The following is a description of a gene set: studied in species Homo sapiens Genes up-regulated in HeLa cells (cervical carcinoma) at 30 min after stimulation with TNF. Tumor necrosis factor alpha (TNF alpha) is a proinflammatory cytokine with important roles in regulating inflammatory responses as well as cell cycle proliferation and apoptosis. Although TNFalpha stimulates apoptosis, it also activates the transcription factor NF-kappa B, and studies have shown that inhibition of NF-kappa B potentiates the cytotoxicity of TNFalpha. Since several chemotherapy agents act like TNFalpha to both promote apoptosis and activate NF-kappa B, understanding the role of NF-kappa B in suppressing apoptosis may have significant clinical applications. To understand the effects of stimulation with TNFalpha and the role of NF-kappa B in regulating this response, a 23k human cDNA microarray was used to screen TNFalpha-inducible genes in HeLa cells. Real-time PCR verified expression changes in 16 of these genes and revealed three distinct temporal patterns of expression after TNFalpha stimulation. Using RNA interference to disrupt expression of the p65 subunit of NF-kappa B, all but two of the genes were shown to depend on this transcription factor for their expression, which correlated well with the existence of NF-kappa B binding sites in most of their promoters. Inflammatory, proapoptotic, and antiapoptotic genes were all shown to be regulated by NF-kappa B, demonstrating the wide variety of targets activated by NF-kappa B signaling and the necessity of differentiating among these genes for therapeutic purposes. Human Gene Set: ZHOU_TNF_SIGNALING_30MIN from publication Zhou A, Scoggin S, Gaynor RB, Williams NS (PMID 12673210), and this is the list of marker genes: DUSP1, JUNB, HDLBP, SLC39A1, CLIC1, SIGMAR1, PTGS2, ATP5MC2, CD5, NFKBIA, IFI27, DDX56, PATJ, PSMB7, PDIA3P1, TNFAIP3, PRDX5, IER2, NDUFA13, HMGA1, KLF10, PHB1, KRT14 (keratin 14), ERGIC3, EEF2, PTMS, TUBB4B, COPS2, CDC123 (cell division cycle 123), PRDX2, PIR, RPL10, CCN1, TMF1, TRAP1, TUBA4A, MCM7, ATF4, IGFBP5, EGR1, CTNNB1, TAGLN2, HSPB1, HNRNPU, CXCL1, SF3B2, MAP2K1, KALRN, MRPL36, PLP2, PPP2R1A